The following is a description of a gene set: Human Gene Set: GOBP_PROTEIN_INSERTION_INTO_MEMBRANE_FROM_INNER_SIDE studied in species Homo sapiens The process in which a protein is incorporated into a lipid bilayer, e.g., the prokaryotic, mitochondrial, or chloroplast inner membrane, from the inner side., and this is the list of marker genes: COX18, MAIP1, OXA1L, BCS1L, TMEM126A